The following is a description of a gene set: Signaling by PI3K/AKT is frequently constitutively activated in cancer via gain-of-function mutations in one of the two PI3K subunits - PI3KCA (encoding the catalytic subunit p110alpha) or PIK3R1 (encoding the regulatory subunit p85alpha). Gain-of-function mutations activate PI3K signaling by diverse mechanisms. Mutations affecting the helical domain of PIK3CA and mutations affecting nSH2 and iSH2 domains of PIK3R1 impair inhibitory interactions between these two subunits while preserving their association. Mutations in the catalytic domain of PIK3CA enable the kinase to achieve an active conformation. PI3K complexes with gain-of-function mutations therefore produce PIP3 and activate downstream AKT in the absence of growth factors. part of: PI3K/AKT Signaling in Cancer species: Homo sapiens Reactome Pathway: Constitutive Signaling by Aberrant PI3K in Cancer, and this is the list of marker genes: PIK3R3, NRG2, TRAT1 (NCBI Gene Id 51488), RAC2, LCK, STRN, FGF16, NRG4, MET, RAC1, TGFA, IRS2, FGF18, SRC, IRS1, PIK3R1, CD19, NRG1, NTF3, CD80, FGFR3, NTF4, FGF8, FGF4, FGF17, HBEGF, KL, FGF10, FGF1, NRG3, FGFR4, AREG (amphiregulin), PIK3CA, PDGFB, HGF, PTPN11, FGF3, ERBB2, EGFR, BDNF, NTRK3, PIK3CB, FGF9 (fibroblast growth factor 9), FGF20, PDGFRA, FGFR1, NTRK2, FYN, PIK3R5, FGF7, BTC, PDGFRB, GRB2, FLT3, FRS2, FGF19, PIK3CD, ERBB3, KIT, CD28, FGF6, ESR1, PIK3R2, FGFR2, CD86, KLB, FGF22, ICOS, FGF2, FLT3LG, RHOG, EREG, PIK3CG, FGF23, GAB2, ERBB4 (erb-b2 receptor tyrosine kinase 4), VAV1, PDGFA, PIK3AP1, FGF5, EGF, GAB1, PIK3R6, EPGN, ESR2, KITLG